The following is a description of a gene set: species: Mus musculus Reactome Pathway: Cellular response to heat stress electronically inferred by orthology from the curated human pathway This event has been computationally inferred from an event that has been demonstrated in another species.<p>The inference is based on the homology mapping from PANTHER. Briefly, reactions for which all involved PhysicalEntities (in input, output and catalyst) have a mapped orthologue/paralogue (for complexes at least 75% of components must have a mapping) are inferred to the other species. part of: Cellular responses to stress, and this is the list of marker genes: Camk2b, Bag4, Hsph1, Nup93, St13, Seh1l, Hspb8, Nup42, Sirt1, Hspa2, Hspa12a, Hsbp1, Cryab, Dnajb6, Hspa12b, Nup155, Nup133, Vcp, Rpa1, Nup205, Bag3 (BCL2-associated athanogene 3), Mapk3, Ywhae, Eef1a1, Ndc1, Hspa1l, Bag1, Nup54, Dnajb1, Aaas, Nup85, Akt1s1 (AKT1 substrate 1), Nup210 (nucleoporin 210), Fkbp4, Nup58 (NCBI Gene Id 71844), Hsf1, Ep300, Rae1, Rps19bp1, Hspa14, Hikeshi